The following is a description of a gene set: Human Gene Set: GOMF_AMINOACYLASE_ACTIVITY Catalysis of the reaction: an N-acyl-L-amino acid + H2O = a carboxylate + an L-amino acid. species: Homo sapiens, and this is the list of marker genes: ACY1, CAT, DARS1, PM20D1, ACY3